The following is a description of a gene set: Human Gene Set: MODULE_265 species: Homo sapiens Caner module 265: IL receptors., and this is the list of marker genes: IL2RB, IL18R1, CXCR2, IL1RAP, IFNGR2, IL4R, IL13RA1, IL15RA, CXCR6, IL1R1, TLR1, IL7R, CXCR4, IFNGR1, TLR2, IL6R, GHR, MYD88, IL1RL1, LEPR, CSF3R, IL10RA, F3, CSF2RB, CXCR5, IL13RA2, IL2RG, IL6ST (interleukin 6 cytokine family signal transducer), IL3RA